Given this list of marker genes TNNT3, MYH3, BIN1, IGFBP5, MYL4, ACTA1, TNNC2, TNNI2, MYOG, MYL11, TNNT2, here is a description of the gene set: from publication de la Serna IL, Ohkawa Y, Berkes CA, Bergstrom DA, Dacwag CS, Tapscott SJ, Imbalzano AN (PMID 15870273) Human Gene Set: DELASERNA_TARGETS_OF_MYOD_AND_SMARCA4 The activation of muscle-specific gene expression requires the coordinated action of muscle regulatory proteins and chromatin-remodeling enzymes. Microarray analysis performed in the presence or absence of a dominant-negative BRG1 ATPase demonstrated that approximately one-third of MyoD-induced genes were highly dependent on SWI/SNF enzymes. To understand the mechanism of activation, we performed chromatin immunoprecipitations analyzing the myogenin promoter. We found that H4 hyperacetylation preceded Brg1 binding in a MyoD-dependent manner but that MyoD binding occurred subsequent to H4 modification and Brg1 interaction. In the absence of functional SWI/SNF enzymes, muscle regulatory proteins did not bind to the myogenin promoter, thereby providing evidence for SWI/SNF-dependent activator binding. We observed that the homeodomain factor Pbx1, which cooperates with MyoD to stimulate myogenin expression, is constitutively bound to the myogenin promoter in a SWI/SNF-independent manner, suggesting a two-step mechanism in which MyoD initially interacts indirectly with the myogenin promoter and attracts chromatin-remodeling enzymes, which then facilitate direct binding by MyoD and other regulatory proteins. studied in species Mus musculus Genes up-regulated in NIH 3T3 cells (fibroblasts) 24 h after inducing MYOD which were down-regulated by dominant negative form of SMARCA4.